Given this list of marker genes Kif1b, Tubb4a, Nsf, Tubb6, Cenpe, Arf5, Kif3c, Kif5b, Arcn1, Tuba1b, Arf1, Tuba3b, Tubb4b, Kif12, Tuba1c, Kifap3, Kdelr1, Stx18, Rab1a, Kif26a, Copb2, Klc3, Racgap1, Kif9, Copg2, Rab1b, Rint1, Kif27, Tuba1a, Kif18b, Tmed3, Kdelr3, Tuba8, Kif2b, Arfgap2, Kif2c, Copg1, Kdelr2, Tubb2b, Klc4, Nbas, Kif20a, Tubal3, Tmed10, Tmed9, Kif21a, Tuba4a, Copb1, here is a description of the gene set: part of: Golgi-to-ER retrograde transport electronically inferred by orthology from the curated human pathway Reactome Pathway: COPI-dependent Golgi-to-ER retrograde traffic studied in species Mus musculus This event has been computationally inferred from an event that has been demonstrated in another species.<p>The inference is based on the homology mapping from PANTHER. Briefly, reactions for which all involved PhysicalEntities (in input, output and catalyst) have a mapped orthologue/paralogue (for complexes at least 75% of components must have a mapping) are inferred to the other species.